The following is a description of a gene set: studied in species Homo sapiens Human Gene Set: HP_ANOREXIA Anorexia, or the loss of appetite for food, is a medical condition. Anorexia, and this is the list of marker genes: SLC46A1, CDKN1A, CDKN2B, CDKN2C, IFNGR1, STAT4, IL12A-AS1, KLRC4 (killer cell lectin like receptor C4), PDCD1, IRF4, SCARB2 (NCBI Gene Id 950), ITGAM, CBS, CD3D, SLC39A4, ATM, MEN1, ATP1A3 (ATPase Na+/K+ transporting subunit alpha 3), SLC19A2, IGHG1, CDKN1B, NPM1, TGFB1, PTPN3, CTLA4, MLX, MMADHC, TREX1, RARA, ASXL1, ALPL, FLI1, PXK, SLC1A3, ZBTB16, P4HA2, HLA-DRB1, NNT, TXNRD2 (thioredoxin reductase 2), C4B, HLCS, IL10, SLC4A1, PALLD, BRCA1, TNIP1 (NCBI Gene Id 10318), DNASE1, RABL3, ARG1, AQP2, OTC, FCGR3B, IRF2BP2, C4A, CBL, MYD88, UBE2L3, MRAP, BRCA2, CALR, UBAC2, MEFV, IRF5, MMUT, HLA-B, ACAT1, CD3E, IL12A, KIAA0319L, GBA1, GLA, BCOR, TNFAIP3, IL12B, STAT5B, ERAP1, TET2, KRAS, IRAK1, PALB2, PML, CR2, NABP1, FCGR2B, AVPR2, CD247, CCND1, PRKAR1A, ATP1A2, NUMA1, CCR1, NFS1, PKHD1, SPP1 (NCBI Gene Id 6696), MC2R, ETS1 (ETS proto-oncogene 1, transcription factor), ROS1, ATRX, JAK2, STAR, BLK, JAZF1, MECP2, STAT3, SRSF2, TLR7, FAS, NAGS, CACNA1A, MPL, IL23R, HMGCL, TLR4, BANK1, PTPN22, SMAD4, CDKN2A, RUNX1, TP53, TNFSF4, FIP1L1, SYK, TBL1XR1